Given this list of marker genes MEF2C, MYOCD, GPER1, KAT2A, TBX5, WNT3A, MIR133A1, MIR145, TGFB2, MIR499A, ARRB2, NKX2-5, MIR1-1, TGFB1, MIR204, BMP4, DHX36, EFNB2, here is a description of the gene set: species: Homo sapiens Any process that activates or increases the frequency, rate or extent of cardiocyte differentiation. Human Gene Set: GOBP_POSITIVE_REGULATION_OF_CARDIOCYTE_DIFFERENTIATION